Given this list of marker genes Pah, Ndufs8, Rab34, Ube2w, Rab13, Mir6961, Mm2pr, Gm13360, Rps26, Ccdc30, Camkv, Mkx, Scarb1, Cry2, Washc2, Slc25a53, Gm16201, Uqcr10, Adamts1 (NCBI Gene Id 11504), Rusc1, Gm16066, Tsen54, Rtf1, Tle3, Ablim1, Cenpu, Kat5, Atg101, Zfpl1, Sash1, Mastl, Nin, Pold1, Prkcsh, Znrf1, Cyb5rl, Gm16510, Cenatac, Prokr2, Cdca5, Gm10637, 9130410C08Rik, Nkiras1, Vps13d, Uspl1, Gm17494, Nup85, Pxylp1, Tbc1d24, Pura, Zfp169, Cdk6, Smarcd2, Tomm40l, Epo, Tmem256, Emc3, Slc6a16, Pdap1, Gm16876, Gnb2 (guanine nucleotide binding protein (G protein), beta 2), Gm12974, Togaram1, Kars1, Nusap1, Rasgrp2, Pfas, Gtf2ird1, Mrpl37, Fntb, Cckar, Slc16a9, 4921507G05Rik, Prpf6, Gpd1l, Ssrp1, Uaca, Jarid2, Smpd3, Hoxaas2, Ccdc63, Gse1, E230016M11Rik, Rab3ip (NCBI Gene Id 216363), Nlgn2, Extl3, Smox, Rpl18, Cabyr, Tgif1, Fancd2os, Jpt1, Mon1b, C030010L15Rik, Luc7l2, Batf3, Sdhc, B4gat1, Gm11447, Mir5621, Nnt, Lrrc75a, Armc8, Lrrc27, Ptch1, Oip5, Bcar3, Rpl8, Pafah1b3, Cibar2, Aktip, Prrg4, Mtss2, Gm6374, Arl15, Anks3, Eif2b2, Snapc3, Psmd11, Gm9530, Gm14216 (NCBI Gene Id 102635751), Gm11716, Cfap97, Aldh16a1, Tomm70a, Septin2 (septin 2), Zmat5, Ndufs3, Cox4i1, Skp2, Slc25a39, Mfsd10, Wbp1l, Dync2i2 (NCBI Gene Id 71820), Nup153, Limk2, Ntaq1, A830005F24Rik, Atp10d, Camk2n1, Cnot1, Cep131, Hdlbp, Agtpbp1, Amt, Hdx, B230307C23Rik, Tmem140, Cpsf4l, C330002G04Rik, Caskin2, Ltbp1, Rbm47, Stx5a, 9030622O22Rik, Gm9951, N4bp2l2, 1700052H01Rik, Snrpa, Zscan12, Gm23113, Ncor2, Snapc4, Usp2, Scaf1, Plxnb1, Mok, Klhl28, Sowahc, Fam110d, Sema4b, Pitpnc1, Arhgap12, Septin10, Nmnat3, P2rx3, Scmh1, Dleu7, Chd9, Gm11962, Sphk2, Slit3, Rps27a, Gramd1b, Glul, Iqsec1, Pimreg, Teddm2, Slc5a5, Ensa, Gli1, Uba2, Sfi1, Lyrm7, Gm10655, Yme1l1, Nuf2, Fancd2 (Fanconi anemia, complementation group D2), Blmh, Stk35, Thrap3, Hoxa2, Cnnm2, Lonrf1, Syne3, Comtd1, Ercc6l2, Rnf130, Nfrkb, Ptch2, Ckb, Igsf9, 2810039B14Rik, Slc12a4, 1700008O03Rik (NCBI Gene Id 69349), Fut10, Trrap, Bud31, Cep112, Mmgt2, Patz1, Mpz, Psmd5, Hyal1, Igsf3, Odad3, Rbm15b, Bbs2, Mir760, Ntrk2, Rps27, Anapc5, Adam5, Tmem64, Fam174c, Hck, Gstm1, Adck1, Pnkp, 4930513N10Rik, Ctsa, Sdad1, Mcemp1, Nck2, H2ac18, Zfp13, 4930527J03Rik, Twf2 (twinfilin actin binding protein 2), Fra10ac1, Kbtbd4, here is a description of the gene set: studied in species Mus musculus Genes containing one or more binding sites for (Gli1) in their promoter regions (TSS -1000,+100 bp) as identified by GTRD version 20.06 ChIP-seq harmonization. Mouse Gene Set: GLI1_TARGET_GENES from publication Yevshin I, Sharipov R, Kolmykov S, Kondrakhin Y, Kolpakov F (PMID 30445619)